Given this list of marker genes SASS6, NR2F6, ACP1, TNRC6C, ENY2, ORC5, TASOR (transcription activation suppressor), PGR, KRAS, CCAR1, SOX6, TTC13, VWA5A, DKK1, MSL2, SMC4, WTAP, HOXA1, MOB1B, ST3GAL2, YWHAG, LIN7C, GXYLT1, PLD1, ASPH, NMI, ZNF440, IGFBP1, SGMS2, NAGA, RIOK3, TMEM33, STYX, MMD, RHOQ, FPR3, CHD6 (chromodomain helicase DNA binding protein 6), EPHA7, ASAP2, FBXW7, EPRS1, CAP2, CREB1, ZNF700 (NCBI Gene Id 90592), AP3B1, RBM11, LYG2, CFHR3, SESTD1, SESN3, LIMD2, CLINT1, CLCN3, ZNF704, TENM1, CYP1B1, SH3BGRL (NCBI Gene Id 96022), ZNF91, TIA1, CLIP1 (NCBI Gene Id 6249), MARK3 (microtubule affinity regulating kinase 3), CDK17, DTD2, TRPA1, ZNF439, ST6GALNAC3, MAPK6, PLCXD3, UHMK1, WWC3, BPTF, MAPK8, ZC3H6, CLTC, LAMC1, CEP57, PRKG2, TNRC6B, ADAM18, MIER1, TMPO, GAN, CD300LF, RECQL, HOOK3, BCAT1, FERMT2, ZNF302, STARD3NL, MFAP5, HNMT, PRKCB, CCDC138, ZNF354C, GFRA1 (GDNF family receptor alpha 1), TOP1, SUCNR1, CEP135, HECW2, CYCS, SMIM19, SLC25A46, AHR, B4GALT3 (NCBI Gene Id 8703), CSPP1, AZIN1, LRRTM2, F13B, DPYSL2, GCLC, NMT2, SEMA6A, C1QC, GOT1, KRT20, ZNF567, ZNF763, ZNF844, GASK1A, SLC17A5 (solute carrier family 17 member 5), SNTG1, MYH9, SMG1, UBE2D2, CHD9, ANKRD12, TBC1D19 (TBC1 domain family member 19), ZNF563, FOXN3, CARNMT1, KDM3B, RAD21, TACR1, OMA1, NCOA2, RAB23, here is a description of the gene set: from publication Chen Y, Wang X (PMID 31504780) Human Gene Set: MIR433_3P species: Homo sapiens Genes predicted to be targets of miRBase v22 microRNA hsa-miR-433-3p in miRDB v6.0 with MirTarget v4 prediction scores > 80 (high confidence targets).